The following is a description of a gene set: studied in species Mus musculus A process in which a protein is transported to, or maintained in, a location within a bicellular tight junction. Mouse Gene Set: GOBP_PROTEIN_LOCALIZATION_TO_BICELLULAR_TIGHT_JUNCTION, and this is the list of marker genes: Tjp1, Flna, Actg1, Actn4, Abcb1a, Cdh5, F11r